Given this list of marker genes MIR27A (NCBI Gene Id 407018), MIRLET7C, SMIM30 (NCBI Gene Id 402587), RABGEF1, WNT5A, BIRC7, PTPN6, ISG15, NLRP6, GIGYF2, MAPKAPK2, NAIP, DNAJA3, HIF1A, OTOP1, DHX9, PPP2CB, ZNF675, MIR130A, IL1R2, CXCR4, PARP14, CDC37, TTLL12, SLIT2, ROBO1, TRAF2 (TNF receptor associated factor 2), LRRC70, MIR24-1, OTULIN, OTUD4, F2RL1, GPS2, DICER1, CARD8, IRGM, MIR1246, NOL3, CLDN18, PTPN2, GSTP1, MIRLET7A1, CD24, NLRC5, IRAK2, PYDC2, IRAK3, STAP1, TMC8, CASP1, HPX, XIAP, RNF113A, MIR138-1, ZBP1, IL6, USP27X, STING1, CASP8, EIF4E2, RIGI, UBE2K, HIPK1, MIR26A1, CCL5, TRIM44, TSLP, AGPAT2, ADAR, TRIM41, RNF185, USP29, TRIM32, ADAM10, FADD, SPHK1, PARP9, MIR27B, PXDN, TAF9, IL1R1, MIR99A (microRNA 99a), RIPK2, RFFL, GAS6, SPPL2B, TANK, MIR20A, CREBRF, YTHDF3, NR1H3, HSPA1A, PTPN11, ULK1, TRIM6, TNFRSF1A, CD74, GFI1, TBK1, MMP8, PYCARD, ARG1, IRF3, PELI3, IFIH1, MMP12, CD40, MAVS, IL36RN, APOA1, TLR4, TREX1, CARD16, ANXA4, ECM1, ANGPT1, AXL, PIAS4, MUL1, LAPTM5, OAS1, PTPN1, CNOT7, IL7, IRAK1, MIR146A, CDK5R1, CASP4, TXK, SIGIRR, CACTIN, MIB2, MIRLET7E, IKBKB, METTL3, PPARG, YTHDF2 (NCBI Gene Id 63042), TAX1BP1, IL1RN, USP18, SAMHD1, CD300LF, MIR29B1, DCST1, CAV1, RIPK1, PADI2, MIR152, PTPRC, NLRP2B, MAP2K5, STAT2, CISH, MIR21, PRKN, MIR101-1, NKIRAS1, PAFAH1B1, EXT1, MIR125B1, SYK, TRIM56, SH2B3, TNFRSF11B, MIR520C, IKBKE, IRF7, TICAM2 (TIR domain containing adaptor molecule 2), IL6ST, ADAM17, SHARPIN, SPATA2, HSPA1B, NRDC, TNFAIP3, NKIRAS2, PIAS3, CYLD, SLIT3, H2BC11, C1QTNF4, EDN1, RBM47, CSF1, ADIPOQ, AGPAT1, TLE5, TLR2, KLF4, MIR125A, OAS3, CCDC3 (NCBI Gene Id 83643), MAPK7, MIR135A1, MIR98, TRAIP, PYDC1, CPNE1, LSM14A, MED1, NR1H4, USP25, TREM2, SPPL2A, PALM3, NR1H2, VRK2, here is a description of the gene set: Human Gene Set: GOBP_REGULATION_OF_RESPONSE_TO_CYTOKINE_STIMULUS Any process that modulates the rate, frequency, or extent of a response to cytokine stimulus. studied in species Homo sapiens